Given this list of marker genes BMP7, SAV1, CNOT1, MIR145, PAX8, PTN, ZC3H13, MYC, BICRA, ACTB, SMARCA4, SMARCD1, PHF10 (NCBI Gene Id 55274), TAF5L, WNT9B, ARID4B, CNOT2, TEAD4, BCL7C, SMARCE1, TAF6L, REST, SINHCAF, ELAVL1, YAP1, NCOA3, ING1 (inhibitor of growth family member 1), BRMS1L, ACTL6B, BICRAL, BCL7B, HMGA2, RBBP7, ARID4A, SMO, BCL7A, SUDS3, DPF2, SMARCC1, TP63, SMARCA2, LOXL2, ZNF706 (zinc finger protein 706), NODAL, SAP130, TAL1, WDR43, RBBP4, KAT2A, TET1, SIN3A, ZNF322, DSG2, PRDM14 (NCBI Gene Id 63978), HDAC2, SMARCB1, BRMS1, OGT, ING2, SIRT6, SS18, ESRRB, HDAC1, ARID1A, HNF1B, KDM2B, BRD9, SAP30, LBH, PAX2, CNOT3, SAP30L, ACTL6A, LNCPRESS1, KDM3A, here is a description of the gene set: Human Gene Set: GOBP_REGULATION_OF_STEM_CELL_POPULATION_MAINTENANCE species: Homo sapiens Any process that modulates the frequency, rate or extent of stem cell population maintenance.